The following is a description of a gene set: Mouse Gene Set: GOBP_MICROGLIA_DEVELOPMENT species: Mus musculus The process aimed at the progression of a microglial cell over time, from initial commitment of the cell to a specific fate, to the fully functional differentiated cell., and this is the list of marker genes: Itgam, Tspan2, Tlr2, Csf1r, App, Nrros